The following is a description of a gene set: Regional abnormality of skin studied in species Homo sapiens An abnormality of the skin that is restricted to a particular body region. Human Gene Set: HP_REGIONAL_ABNORMALITY_OF_SKIN, and this is the list of marker genes: RAPSN, CBL, NFKB2, DPH1 (NCBI Gene Id 1801), LIMK1, JARID2, ATP6V0A2, GJA8 (NCBI Gene Id 2703), SDHC, SHOC2, HPGD, AAAS, IL36RN, MSL3 (NCBI Gene Id 25867), CCDC22, SLC18A3, EMC1, KDM4B, RNU4ATAC, STS, RTEL1, FLVCR2, BRAF, CREBBP, SLURP1, TCF4, NAA10, PEX12, H3-3B, ATP2A2, LAMC2, C1R, UBE3B, EYA1 (NCBI Gene Id 2138), ERCC5, CIB1 (calcium and integrin binding 1), IRF6, CTLA4, GRHL2, PPP3CA, PORCN, HCCS, PEX3, TOE1, POLRMT, TSEN2, DSE, DDX11, SEC23B (SEC23 homolog B, COPII coat complex component), PUF60, BRD4, GJB4, HOXA13, NECTIN1, KIF14, MCTP2, CKAP2L, RIPK4, SLC39A4, ATN1, BAZ1B, VPS37D, KRT2 (keratin 2), IFNG, PIGS, BLM, PEX26, MTX2, IFT122, NFIX, KDF1, RPS23, TMEM147, DDX59 (DEAD-box helicase 59), DSP, KDSR, RRAS2, MED12L, DIS3L2, CD28, KRT83, NEXMIF, DHODH, CPLX1, LRP4, CAST, RETREG1, MEGF8, TUBA1A, GTF2IRD1, DSG1, CEP55, TSEN15, MMP1, LETM1, HSPG2 (NCBI Gene Id 7796), TRIO, MBTPS2, ROR2, USF3, SLC25A24, GTF2I, CHRND, TELO2, SLCO2A1, JUP, NGLY1, SDR9C7, PEX11B, FIG4, POMP, PGM2L1, ADGRG6, TUFT1, TINF2, NBAS, ALOX12B, MMP2, TP63, PIK3CA (NCBI Gene Id 5290), KMT2D, KATNB1, PDHA1, SRD5A3, TGM5, TYMS, ABCA12, TBX4, TBCK, NHP2, ALPK3, RHBDF2, MEG3, NXN, AUTS2, BMP4, DNAJC30, LDHA, ALDH6A1, SDHD, LAMA3, ERCC6, FKBP6, STAT3, ZNF462, GJB2, RERE, TMEM270, PIGQ, ALOXE3, TRPV3, MCOLN1, ERGIC1, TAF4, TASP1, PEX5, B3GLCT, AP1B1, COX7B, KCNH1, THOC2, BHLHA9, ASXL2, PEX19, NSDHL, ZC4H2, CTSB, GTF2IRD2, CFTR, IL1R1, FERMT1, CTC1, GPR101, EIF4H, TSHR, NDUFB11 (NADH:ubiquinone oxidoreductase subunit B11), MAP2K2, CHST14, CDSN, PTPRF, WRAP53, NUP88, PSENEN, ESCO2, PERP, NAA20, ABCC9, CSGALNACT1, SOS2, PARN, PTEN, KANK2, NALCN, KRT16, GLYCTK, PACS1, CSTA, POFUT1, DEAF1, COG1, FBXO11, VPS33B, LSS, H4C9, MAGEL2, TSEN34, TPM2, LORICRIN, TSC1, TRIM37, SMS, XYLT1, CHRNG, H4C5, PEPD, AKT1, AIP, FGFR2, SMC5, POU1F1, ZMYM2, GPKOW, NOG, NR2F1, SMAD2, KRT6A, TERC, WNK1, COG6, U2AF2, KANSL1, WDR37, RB1, DOK7, ITGA6, PLOD1, EZH2, CHUK, COL25A1, SASH1, RRAS, SCYL2, UBR7, ARL3, EHMT1, ITGB4, VPS13B (vacuolar protein sorting 13 homolog B, NCBI Gene Id 54990), ERCC2, USB1, SMARCA2, KAT6B, MUSK, WAC, CAPRIN1, TGDS, AP1S3, TSEN54, VAC14, LIFR, STXBP1, PNPLA6, EFNB1, DHCR7, LAMB3, TERT, CHRNA1 (cholinergic receptor nicotinic alpha 1 subunit), HDAC4, RUSC2, AQP5, CCBE1, SOX18, PLOD3, MTFMT, GRIN1, GDF5, PEX13, MYOD1, ELN, PIEZO2, UFC1, GPC6, CILK1, MRAS, ERCC4, RPL10, GNB2, SMOC1, FILIP1, EXT1, NDE1, SPECC1L, IRX5, CTBP1, RASA2, POGLUT1, SLC39A13, ADNP, SET, APC, ZNF469, OTUD5, LZTR1, DEPDC5, LTBP4, CD4, COL14A1, KIF1A, DKC1, MAP1B (microtubule associated protein 1B), POLR1A, CTSC, CERS3, SLC35C1, KLLN, BMPR1B, RSPO1, PAX3 (paired box 3), PEX1, COL17A1, RTL1 (retrotransposon Gag like 1), XPC, PTCH2, TSC2, NSD2, TNNI2, KRT6C, SPRED2, LTBP1, KRT10, WRN, CARD14, CD96, MYH3, DLX4, NECTIN4, MAP3K7, FOXP1, EXTL3, KRT17, SDHB, GMPPA, CHST3, G6PC3, IGF2, KLK11, CHD7, NIPAL4, BRF1, CYP27A1, PITX1, FLNA, IVNS1ABP, SPRTN, ATP6V1B2, KIF21A, PIGN, SNAP29 (NCBI Gene Id 9342), STING1 (stimulator of interferon response cGAMP interactor 1), PEX14, GJA5, RIN2, PPP2R3C (NCBI Gene Id 55012), KCNJ8, PKP1, GJB6, EP300 (E1A binding protein p300), MMP14, IFT43, KRT14, FBXO28, MST1, ASXL1, TAT, FKBP10, PHGDH, SPTBN1, CYP4F22, ADAMTS15 (ADAM metallopeptidase with thrombospondin type 1 motif 15), HNRNPK, HNRNPH2 (NCBI Gene Id 3188), DST, H3-3A, RAB3GAP2, KRT85, DPH2, SERPINA12, PAK3, TRAPPC11, KPTN, TBL2, AAGAB (NCBI Gene Id 79719), FOXP2, ANAPC1, EBF3, GJB3, SOS1, IGF1, KDM6A, KRT6B, CEBPE, RPS6KA3, KMT2A, CHD1, B4GALT7, NIPBL, DSC2, ITCH, CLIP2, CDC42BPB, NUP188, METTL27, PEX6, KRT74, TBL1XR1, LIG4, SMPD4, NPM1, DOCK6, FGFRL1, RAB11B, IFT57, TNNT3, PDGFRB, AHDC1, BCOR, TBX5, PEX10, SULT2B1, YY1, TNFRSF1B, KCNN3 (potassium calcium-activated channel subfamily N member 3), RAD21, GPR35, ARID1B, RBM10, PIGL, DDB2, ZFX, NOP10, SEPSECS, CTCF, TWIST2, ZNF407, FGF9 (NCBI Gene Id 2254), PLOD2, KRT9, DHX30, PLAA, VPS51, PRKD1, UBR1, COX14, WNT10A, PNPLA1 (NCBI Gene Id 285848), CEP57 (NCBI Gene Id 9702), KRT5, FLG, DLK1, PEX2, LONP1, CCNQ, PRR12, CDK19 (NCBI Gene Id 23097), KCNK9, SLC25A12, PKDCC, TCF12, GLE1, VPS33A, SUFU, PLEC, LMX1B, BUD23, ASXL3, PIGA, CDK10, SMC3, MED12, HDAC8, CCDC32, ATR, SMARCAD1, RFC2, TAF6, KRAS (NCBI Gene Id 3845), CCN2, ZNF292, TRPS1, COL7A1, XPA, ANKRD11, LBR, PTCH1, GJA1, STAG1, NLRP1 (NCBI Gene Id 82286), STX1A, ENPP1, NUP107, SMC1A, AFF3, ADAM17, SERPINB7, RECQL4, SEMA4D, TGM1, CLCN7, RIT1, ATP6V1A, FGD1, GSN, DPYD, ACVRL1, PPP2CA, RNU4-2, HRAS, PEX16, CST6, RAF1, MED25, TWIST1, FGFR3, TRIM8, NCF1, SCN9A, KLHL24, NRAS, TRPM4, PTPN11, KRT1, ERCC3, MAP2K1, ADAMTSL1, MEF2C, SETBP1, SALL4, RAB3GAP1, DPAGT1, CSNK2A1, BICD2, PPP1R13L, TFAP2A, MTOR, PAX1